Given this list of marker genes Chmp4b, Chmp3, Chmp4c, Chmp7, Eml3, Cep97, Chmp2b, Chmp5, Hspa1b, Chmp1b2, Ccsap, Vps4b, Plk1, Rcc1, Hnrnpu, Chmp6, Chmp1a, Chmp2a, Chmp1b, Ripor2, Tpr, Drg1, Hspa1a, here is a description of the gene set: species: Mus musculus Any process that modulates the frequency, rate or extent of mitotic spindle assembly. Mouse Gene Set: GOBP_REGULATION_OF_MITOTIC_SPINDLE_ASSEMBLY